The following is a description of a gene set: from publication Chen Y, Wang X (PMID 31504780) species: Mus musculus Mouse Gene Set: MIR_3965 Genes predicted to be targets of miRBase v22 microRNA mmu_miR_3965 in miRDB v6.0 with MirTarget v4 prediction scores > 80 (high confidence targets)., and this is the list of marker genes: Slc30a4, Ptbp3, Srsf5, Fgd4, Pcdh9, Cct6a, Cpne8 (NCBI Gene Id 70271), Etv1, Zfp442, Cntn4, Sntn, Crk, Zscan26, Zfp449 (NCBI Gene Id 78619), Zfp26, Trp63, Zc3h18, Trim68, Sec63, Zfp715, Zfp704, Myorg, Cep68, Epm2aip1, Rala, Rpa1, Robo2, Ccl1, Setbp1, Agpat3, Tnfrsf1a, Spock1, T2, Stag2, Ptpn4, Chml, Tmem68, Usp27x (ubiquitin specific peptidase 27, X chromosome), Nrep, Sowahc, Fam204a, Fasl, Slc19a3, Asxl3, Farp1, Ormdl2, Brms1l, C1ql3, Vsig1, Tenm3, Esr1